Given this list of marker genes SH3BP5, TMEM169, CDK14, SV2C, DNAJC12, TMCC3, MGAT4C, VSTM2A, PLCXD3, TMEM132B, C22orf42, TOX2, MAP7D2, DGKE, RCAN2 (NCBI Gene Id 221402), ENPP4, FHOD3, ANK3, PDZRN4, CACNA1B, CASKIN1, PTPN3, NALCN, JAKMIP1, PCDH17, EPB41L4B, HOOK1, JPH3, TPBG, MAPRE2, JPT1, GRP, CGN, KCTD4, POU6F1, MMP24, DKK3, ASB4, TACC2, PAPPA, DOCK3, SYT13 (synaptotagmin 13), FBLL1, PPFIA2, NOL4, XPR1, BNC2, KIAA1549, SYNPR, RNF17, ZNFX1, GPR26, DOK6, ZC2HC1A, MIAT, CDH8, CDON, CELF4, ARG2, MTUS2, FBXL16, CLDN1, GRIP2, KCNJ6, BEX5, MTURN, GABRB1, HBA2, C6orf118 (NCBI Gene Id 353266), HERC2P2, PNMA2, SRCIN1, DIRAS2, GABRB3, BTBD1, TSPAN7, WSB2, NTSR1, GARNL3, ENTREP2, ABCA3, SEMA6C, CD24, SCN9A (sodium voltage-gated channel alpha subunit 9), PLA2G4C, ATP9A (ATPase phospholipid transporting 9A (putative)), REEP2, C1QL1 (NCBI Gene Id 10882), RUFY3, NYAP1, PHYHIPL, GPC2, ROBO1, NAPB, FUT9, TSIX, POU3F2, SLC9A7, SCN2A, TAC1, PDZD7, SLC4A3, FRY, NCAM1, CNR1, MYRIP, SNX1, SH3GL3, ERC2, RUSC1, NIPA1, CNTN5, STMN1, NRXN2, CBLN4, TXN, RAB9B, SNTG1, CHRNA6, HPRT1, RAB3C, MEST, ELOVL4, RIMS1, PFKP, REEP1, GABRA2, LRRC49, PLPPR4, C1orf35, SEZ6L, BASP1, MPP2, ACOT7 (NCBI Gene Id 11332), DSCAM, ANKH, MIR3917, GABRG2, CHL1, PNCK, GNAO1, BSN, UBE2QL1, DIRAS3, VGF, PCDHB4, CHRNA7, BICRAL, CHST1, CPEB3, RASGRF2, NFASC, ABCC8, LY6H, PLPPR2, KCNIP4, SCG5, SLC18A1, CBLN2, B4GALNT1, MYCBP2, LMO4, CDK5R1, FADS3 (fatty acid desaturase 3), ENO2, MEG3, DUSP4, MAP1B, PBX1, GRM5, TRIM36, KIFC2, NDRG4, ULK2, EEF1A2, SNAP25, LHFPL4, RALYL, CHRNB3, SYT7, RNF112, ELAVL2, CTNNA2, CDKL2, NEDD4L, ALDH1A1, SHISAL1, GRIK3, ARHGEF3, SRRM4, DOP1A, RIMBP2, CYP4X1, NR4A2, DDC, LONRF2, TRIM46 (tripartite motif containing 46), PDP1, PEX5L, SLITRK5, TLCD3B, APBA1, TMEM35A, SLC22A15, ROBO2, RIMS3, SOX6, CACNG8, OSBPL6, RERG, NAP1L3, MYT1, NLN, GOLGA3 (NCBI Gene Id 2802), UCHL1, PHACTR3, PDE1B, NKAIN2, GRIA3, JPH4, PID1, SPINT2, SLITRK1, SHTN1, EN1, SLC18A2, SDC2, CACNA1A, GNAL, IPCEF1, ATP1B1, DOK4, PDE4D, SULT4A1, FXYD6-FXYD2, SNORD116-29, REV3L, SHF, CHMP2B, CADPS, BAALC, SERINC1, PAK3, POU2F2, MLLT11, KLHL13, CALN1, GFRA1, CACNG4, JUP, TMEM59L, RASGEF1B, LGI2, KIF21B, ZNF813, DEAF1, LRRC7, SLC6A3, FAM184A, LRFN5, CEP126, BEX2 (NCBI Gene Id 84707), SV2B, CD2, EN2, AKR1C1, GPRIN3, CELF3, TUBB2B, IKZF4, GRIA2, NKAIN1, DNM3, GPR12, DPP6, DYNC1I1, APLP1, MAP2, DMTN, DCX, CXADR, MCC, FAIM2, GABARAPL1, NREP, VWA5A, KIFAP3, SLC1A4, PRRT4, LRRTM4, ATP8A2, PLXNA4, SYN2, TUBA1A, BRSK1, KLHL1, BEGAIN, NTM, ST8SIA3, RAB3B, CNTNAP2, ZNF697, B4GALT6, ZFHX3, LMO3, PSD, LRRTM2, NNAT, TRIM67, SMIM18, RALGDS, SCN3A, DNAH2 (NCBI Gene Id 57637), HBG2, SDC1, NPY1R, KCNN3, TPPP, RIMS2, FGF13, ASXL3, ABLIM3, LRRC37A3, AATK, SNCA, CHRNA4, RGS6, GPRASP1, DNAJC6, KRT5, ACTL6B, FOXA1 (NCBI Gene Id 3169), BLCAP, SCN3B, FNBP1L, ATP1A3, USP49, TBC1D3, ANKRD44, PIANP, KCNC2, TUBB3, STMN2, ENOX1, DLG2, CRMP1, SEZ6L2, PACS1 (phosphofurin acidic cluster sorting protein 1), OLFM3, TH, SLC8A2, FRMPD3, AKR1C2, CAMK2N1, LGI1, PCSK2, TMEM151A, PITX3, ZCCHC12, CHD5, CMIP, TMEM196 (NCBI Gene Id 256130), SOBP, EPHA5 (NCBI Gene Id 7304), UBASH3B, CELF5, CDH4, OPN5, CDH13, LRRC3B, FKBP1B, PRKCB, L1CAM, EID2B, PKIA, ARHGAP28 (Rho GTPase activating protein 28), SCN8A (sodium voltage-gated channel alpha subunit 8), HBG1, KLHL29, SLC6A15, CSMD2, TCEAL5, TMEM121B, PGAP4, FRMPD4 (FERM and PDZ domain containing 4), IGF1, ALX4, SSTR2 (somatostatin receptor 2), HPCAL4, SYP, CCDC85A, TTR, KRT17, DRAIC, ENHO, AMER3, FGF9, RAP1GAP2, ATCAY, DLK1, KLC1 (NCBI Gene Id 3831), NALF1, LRRC55, STMN4, SH3PXD2A, SCARNA1, DCC, PAK5, PTPN5, GNG3, PBX3, SLC17A6, SYT4, PRKAR2B, KRT222, SMPD3, C12orf76, TMEM178B, AMN1, CDKN2D, TUB, BEX1, CALB1, DPYSL3 (dihydropyrimidinase like 3), SHROOM2, TUBB2A, ELOVL3, ELAVL4, VSNL1, SBK1, GPM6A, NMNAT2, STXBP1, PRKCA, SLITRK4, CALHM6, PSD2, DPP7, RUNDC3A (RUN domain containing 3A), PRL (prolactin), PIK3CD, RTN1, NSG2, PDE2A, GNPTAB, STXBP5 (NCBI Gene Id 134957), GOLGA8B, PRKACB, AK5, PLXNC1, PIK3R1, RET, COL11A1, HBB, SPIN4, PGM2L1, PDE1A, NPAS4 (NCBI Gene Id 266743), C19orf12, RBFOX2, SEMA6D, MPPED2 (NCBI Gene Id 744), MYO5A, SOX11, MAST1 (microtubule associated serine/threonine kinase 1), HMGCLL1, PDE11A, CSMD1, C10orf95-AS1, XKR6, RASA4, CNTN1, NRXN3, PLEKHA6, PCDH1, ERBB4, MYT1L, BDNF, NSG1, INSM1, GPR85, TMOD2, CNTN4, CD27-AS1, RETREG1, SNAP91, RUNDC3B, ARK2C, ADARB2, OPRK1 (opioid receptor kappa 1), CACNA1E, EPB41L1, CSRNP3, CACNG2, GAP43, DRD2, ST8SIA2, SCAMP1, FLRT3, XKR4, OPTN, NETO2, INA, HBA1, SERTAD4-AS1, AJAP1, SHANK2, CORO2A, PRRT2, CREG2, SV2A, KLHL32, RNF125 (ring finger protein 125), here is a description of the gene set: Human Gene Set: MANNO_MIDBRAIN_NEUROTYPES_HDA2 from publication La Manno G, Gyllborg D, Codeluppi S, Nishimura K, Salto C, Zeisel A, Borm LE, Stott SRW, Toledo EM, Villaescusa JC, Lönnerberg P, Ryge J, Barker RA, Arenas E, Linnarsson S (PMID 27716510) Cell types are named using anatomical and functional mnemonics prefixed by 'm' or'h' to indicate mouse and human respectively: OMTN, oculomotor and trochlear nucleus; Sert, serotonergic; NbM, medial neuroblast; NbDA, neuroblast dopaminergic; DA0-2, dopaminergic neurons; RN, red nucleus; Gaba1-2, GABAergic neurons; mNbL1-2, lateral neuroblasts; NbML1-5, mediolateral neuroblasts; NProg, neuronal progenitor; Prog, progenitor medial floorplate (FPM), lateral floorplate (FPL), midline (M), basal plate (BP); Rgl1-3, radial glia-like cells; Mgl, microglia; Endo, endothelial cells; Peric, pericytes; Epend, ependymal; OPC, oligodendrocyte precursor cells. studied in species Homo sapiens